Given this list of marker genes Isg20, Exd2, Pole, Meiob, Polg, here is a description of the gene set: Catalysis of the sequential cleavage of mononucleotides from a free 3' terminus of a single-stranded DNA molecule. Mouse Gene Set: GOMF_SINGLE_STRANDED_DNA_3_5_DNA_EXONUCLEASE_ACTIVITY studied in species Mus musculus